The following is a description of a gene set: Mouse Gene Set: REACTOME_SIGNALING_BY_ERBB4 Signaling by ERBB4 studied in species Mus musculus, and this is the list of marker genes: Wwp1, Wwox, Psen1, Aph1b, Esr1, Btc, Nrg3, Grb2, Stat5a, Pik3r1, Egfr, Src, Erbb4, Egf, Hras, Kras, Rps27a, Itch, Nedd4, Erbb3, Yap1, Uba52rt, Ubb, Pik3ca, Sos1, Ereg, Uba52, Psenen, Hbegf, Ncstn, Nrg1, Shc1, Ubc, Aph1a